The following is a description of a gene set: from publication Hebert JD, Myers SA, Naba A, Abbruzzese G, Lamar JM, Carr SA, Hynes RO (PMID 32019869) studied in species Homo sapiens Human Gene Set: HEBERT_MATRISOME_TNBC_LUNG_METASTASIS We have previously developed methods for enriching tissue samples for their ECM protein content by taking advantage of the relative insolubility of the ECM, and we have used these techniques in conjunction with mass spectrometry-based proteomics to profile the matrisome, the complete collection of both core ECM and ECM-associated proteins, in several different cancers. Here we define and compare the ECM components of metastatic niches and how they differ among the specific secondary sites common in TNBC. For this purpose, we use as a model the MDA-MB-231 human TNBC cell line, originally derived from a patient pleural effusion (24), which is capable of metastasizing to the brain, lungs, liver and bone marrow in mouse xenografts. We identify which ECM proteins are commonly elevated at multiple different metastatic sites, and which are preferentially elevated in particular sites. We investigate how these specific ECM proteins, as well as the tumor matrix overall, are differentially produced by the tumor and stromal cells; in this paper, we use stromal to include all cells in the tumor that are not tumor cells. These comparisons did not simply identify the most elevated proteins in each tissue, but rather the proteins most significantly different in abundance in one tissue relative to all others. Separate analyses were conducted for tumor-cell-derived (human) and stroma-derived (mouse) proteins. In this study, we performed an unbiased, quantitative mass spectrometric survey of ECM proteins present in MDA-MB-231 breast cancer xenograft metastases to the brain, lungs, liver and bone marrow. This gene set lists the matrisome proteins found in significantly higher abundance in TNBC lung metastasis niche compared to TNBC bone, liver and brain metastatic niches. Matrisome proteins found in significantly higher abundance in TNBC lung metastasis niche compared to TNBC bone, liver and brain metastatic niches., and this is the list of marker genes: LAMB3, FBLN5, COL3A1, COL7A1, COL4A3, LAMA3, HSPG2, LAMA1, COL4A4, LAMA5, COL4A5, LAMC2, SFTPA1, COL4A2, LUM, BGN, MFAP4, LAMC1, COL4A1, LAMB2, TNXB, ELN, NID1